The following is a description of a gene set: electronically inferred by orthology from the curated human pathway This event has been computationally inferred from an event that has been demonstrated in another species.<p>The inference is based on the homology mapping from PANTHER. Briefly, reactions for which all involved PhysicalEntities (in input, output and catalyst) have a mapped orthologue/paralogue (for complexes at least 75% of components must have a mapping) are inferred to the other species. part of: Metabolism of RNA species: Mus musculus Reactome Pathway: Processing of Capped Intron-Containing Pre-mRNA, and this is the list of marker genes: Magoh, Mettl14, Snrpa1, Rnf113a2, Ppp1ca, Tut1 (terminal uridylyl transferase 1, U6 snRNA-specific), Nup42, Smndc1, Prpf19 (pre-mRNA processing factor 19), Hnrnpf, Polr2e, Polr2b, Dhx8, Casc3, Seh1l, Polr2i, Pcbp1, U2surp, Snw1, Snip1, Lsm8, Gtf2f1, Fam32a, Prpf18, Ppig, Cdc40, U2af1l4, Zmat5, Snrpg, Snrpn, Ndc1, Hnrnpk, Nup93, Sf3b5, Papolg, Nup133 (nucleoporin 133), Mfap1a, Snrpa, Snrnp25, Clp1, Polr2f, Sf3a3, BC005624, Nup85, Cpsf1, Rnf113a1, Lsm2, Hnrnph1, Dhx16, Srrm2, Alyref, Snrnp40, Slbp, Nup58, Rae1, Eftud2, Zfp830, Pcbp2, Nxf7, Ctnnbl1, Rbm22, Thoc6, U2af2, Steep1 (NCBI Gene Id 77644), Wdr33, Dhx35, Sarnp, Lsm4, Yju2, Gtf2f2, Hnrnph2, Nup155, Nsrp1, Prcc, Ddx39a, Ppil2, Syf2, Magohb, Thoc3, Snrnp35, Prpf3, Upf3b, Ubb, Ddx41, Polr2c, Rps27a, Nup205, Nkap, Srsf5 (serine and arginine-rich splicing factor 5), Polr2a, Srsf3 (NCBI Gene Id 20383), Rbm5, Nxf2, Usp39, Rnps1, Ik, Sugp1 (SURP and G patch domain containing 1), Ubl5, Srsf10, Mtrex, Polr2k, Tfip11, Ddx23, Wbp4, Polr2l, Cactin, Cpsf3, Snrpf, Zcrb1, Luc7l3, Xab2, Nup210, Bud13, Lsm6, Phf5a, Sart1, Thoc7, Prkrip1, Srrt, Mfap1b, Prr3, Ptbp1, Fip1l1, Srsf8, Rbm17, Papola, Gpatch1, Sde2, Dhx15, Ppil1, Rbmx, Hnrnpr, Snrpc, Cwc27, Cdc5l, Snu13, Prpf4, Aaas, Nup54, Snrnp27, Leng1